The following is a description of a gene set: High hypermetropia Human Gene Set: HP_HIGH_HYPERMETROPIA species: Homo sapiens A severe form of hypermetropia with over +5.00 diopters., and this is the list of marker genes: BUD23, LCA5, STX1A, TUBB4B, SOX2, MFRP, IFT122, CEP78, FKBP6, WDR45, FGF3, IFT43, SKI (NCBI Gene Id 6497), WDR19, PIK3R1, SPEN, FZD5, GABRD, RAX, LUZP1, GTF2IRD1, MMP23B, CSTA, SLC6A6, PRDM16, BEST1, NMNAT1, TGM5, PRKCZ, DNAJC30, KCNAB2, RFC2, CLIP2 (NCBI Gene Id 84805), CIB2, PRSS56, TMEM98, PDPN, WDR35, TOMM7, RMRP, RERE, EIF4H, OGT, LRMDA, RPGRIP1, CASZ1, MYO7A (NCBI Gene Id 4647), SMAD4, HARS1, USH1G, TMEM270, ALDH1A3, ELN, NCF1, UBE4B, ARSG, RAI1, ARV1, MT-TS2, LIMK1, IFT52, TBL2, SIX6, VPS37D, GJA1, ESPN, USH1C, CLRN1, TAOK1, HSPG2, CDH23, GTF2I, BAZ1B (NCBI Gene Id 9031), METTL27, PCDH15, GTF2IRD2, BLOC1S3, CRB1, CNNM4, ZMYM2, OTX2, MED25